The following is a description of a gene set: Phosphoinositide 3-kinase (PI3K) family Human Gene Set: WP_PHOSPHOINOSITIDE_3KINASE_PI3K_FAMILY studied in species Homo sapiens, and this is the list of marker genes: PIK3R6, PIK3CG, PIK3R3, PIK3R5, PIK3CA, PIK3CD, PIK3R2, PIK3CB, PIK3C2G, PIK3C2B, PIK3C2A, PIK3R1, PIK3R4